Given this list of marker genes VSIG4, CX3CL1, PTPRC, BPI, TAFA3, MIR130A (microRNA 130a), LDLR, SYT11, CD200, NR1H3, FAM76B, ADGRF5, ZC3H12A, GRN (NCBI Gene Id 2896), NR1D1, FCGR2B, CST7 (NCBI Gene Id 8530), IL31RA, LRFN5, here is a description of the gene set: Any process that stops, prevents, or reduces the frequency, rate or extent of macrophage activation. Human Gene Set: GOBP_NEGATIVE_REGULATION_OF_MACROPHAGE_ACTIVATION studied in species Homo sapiens